The following is a description of a gene set: Neighborhood of ESPL1 studied in species Homo sapiens Neighborhood of ESPL1 extra spindle poles like 1 (S. cerevisiae) in the MORF expression compendium Human Gene Set: MORF_ESPL1, and this is the list of marker genes: YARS1, CSNK2B (NCBI Gene Id 257616), NSD2, GNB1 (G protein subunit beta 1), ZWINT, TRIM28, MFAP1, ATP5MC3, SSBP1, TYMS, FOXM1, NUDC, SNRPA, PTGES3 (NCBI Gene Id 10728), DNAJC9, DDX19B, TFDP1, ATP5PO, HCFC1, GOT2, GLO1, PSMB2, DNMT1, HNRNPA2B1, MCM2, RFC4, KIFC1, FUS, MCM3, AURKB (NCBI Gene Id 9212), LMNB2, TARDBP, RAD23A, HAT1, MCM6, CYCS, VDAC1, BUB1, BUB1B, BUB3, H2AZ1, PLK1, PPP1CC, BAZ1B, NUDT1, HNRNPAB, FEN1, HNRNPD, AFG3L2, KHSRP, SSRP1, PPM1G, CCT5, CS, POLA2, CLPP, KIF11, CHERP, RRM1, PRPS2, ESPL1